The following is a description of a gene set: part of: Chromosome Maintenance species: Mus musculus electronically inferred by orthology from the curated human pathway Reactome Pathway: Telomere Maintenance This event has been computationally inferred from an event that has been demonstrated in another species.<p>The inference is based on the homology mapping from PANTHER. Briefly, reactions for which all involved PhysicalEntities (in input, output and catalyst) have a mapped orthologue/paralogue (for complexes at least 75% of components must have a mapping) are inferred to the other species., and this is the list of marker genes: Pcna, H2bc12, Pold1, Ppp6c, H2bc27, H4c17, Terf1, H2ac13 (H2A clustered histone 13), H2ac6, H2ac1 (H2A clustered histone 1), Dna2, Terf2, Rfc3, Tert, Ten1, Pold4, H4c1, H2ac23 (NCBI Gene Id 665433), Rfc1, H4c8, Acd, H4c3, H4c11, Daxx (Fas death domain-associated protein), H2ac22, H2ac19, H4c9, Chtf18, H2bc15, H2ac24, Chtf8 (NCBI Gene Id 214987), H2az2, H2ac4, H4c6, H2ac12, H2bc9, Nop10, H2ac10, H2ac20, H3f3a, H4c12, H2bc8, H4c18, Shq1, H2bc3, H4c4, Blm, Pola2, H4c14, Rpa1, H2bc1, Pola1, H2bc7, H2bc22, Ccna1, Lig1, Wrn, H2ax, H2bc11, Ctc1, Wrap53, H2ac15, H2ac11, H4c2, Dscc1, H2bc13, Prim1, H2ac7, Pif1, H2ac8, Pold2